Given this list of marker genes Pik3c3, Pik3c2a, Fig4, Mtmr7, Mtmr2, Mtmr4, here is a description of the gene set: electronically inferred by orthology from the curated human pathway species: Mus musculus Reactome Pathway: Synthesis of PIPs at the late endosome membrane part of: PI Metabolism This event has been computationally inferred from an event that has been demonstrated in another species.<p>The inference is based on the homology mapping from PANTHER. Briefly, reactions for which all involved PhysicalEntities (in input, output and catalyst) have a mapped orthologue/paralogue (for complexes at least 75% of components must have a mapping) are inferred to the other species.